Given this list of marker genes COL4A2, LGALS1, TGFB1, S100A6, ITIH2, TGFBI, FN1, FBLN2, COL16A1, ITIH1, ECM1, COL8A1, IGFBP7, CBLN2, EMILIN2, LTBP1, ANXA2, TNC (NCBI Gene Id 3371), POSTN, EMILIN1, FBN2, COL7A1, MFAP5, COL6A2, COL12A1, PLG, VTN, here is a description of the gene set: Matrisome proteins detected exclusively in highly proliferative head-and-neck squamous cell carcinoma human-to-mouse xenografts (T-Hep3) compared to dormant head-and-neck squamous cell carcinoma human-to-mouse xenografts (D-Hep3). studied in species Homo sapiens By using ECM proteomics we have defined the matrisome of dormant cancer cells vs proliferative cancer cells of head and neck squamous cell carcinoma (HNSCC). To do so, we used established cellular dormancy models and their proliferative counterparts: proliferative (T-HEp3) and dormant (D-HEp3) HNSCC. To investigate the matrisome composition of these dormant and proliferative tumors, we performed ECM-enriched mass spectrometry using decellularized T-HEp3 tumors and D-HEp3 dormant nodules grown in mice. Analysis of indolent D-HEp3 dormant nodules and aggressive T-HEp3 tumors grown in mice show a significant dysregulation of the matrisome signature. This gene set lists the matrisome proteins detected exclusively in highly proliferative HNSCC human-to-mouse xenograft compared to dormant HNSCC human-to-mouse xenograft. We further excluded proteins that were detected in only one of the three proliferative samples. from publication Di Martino JS, Nobre AR, Mondal C, Taha I, Farias EF, Fertig EJ, Naba A, Aguirre-Ghiso JA, Bravo-Cordero JJ (PMID 35121989) Human Gene Set: DI_MARTINO_MATRISOME_HIGHLY_PROLIFERATIVE_HNSCC